The following is a description of a gene set: Lymphoproliferative disorder Human Gene Set: HP_LYMPHOPROLIFERATIVE_DISORDER species: Homo sapiens, and this is the list of marker genes: ITK, PRKCD, LRBA, CD27, KRAS, NRAS, STK4, CD70, MAGT1, CTPS1, WAS, SMARCAL1, ZAP70, ADA2, MCM4, IL2RG, MYD88